The following is a description of a gene set: studied in species Homo sapiens from publication Yevshin I, Sharipov R, Kolmykov S, Kondrakhin Y, Kolpakov F (PMID 30445619) Human Gene Set: SIPA1_TARGET_GENES Genes containing one or more binding sites for (SIPA1) in their promoter regions (TSS -1000,+100 bp) as identified by GTRD version 20.06 ChIP-seq harmonization., and this is the list of marker genes: RNU6-821P, WDR46, MIR548AQ, HMGN1P4, USP2-AS1, RCOR3, IL31RA (interleukin 31 receptor A), NDUFAF8 (NCBI Gene Id 284184), CEP97, USF3, H2AC14, TGIF2, MTCO3P12, TRIM26, EDA, OPTN, TK1 (thymidine kinase 1), CCDC91, DENND3 (NCBI Gene Id 22898), NNT, NUDCD2, H2BC17, MT-TL1, CXCL8, EBLN3P, GLUD1P2, TGFBR1, CYB5A, BICRAL, IQCH, CLUAP1, CACNA1A, KCNK2, HMMR, PIK3C3, EIF4B, API5, LINC02098, KCNJ1, DST, BRD8, LINC00708, LYPLA2P2, HLA-E, H3C12, PARP2, MOSPD3, MRPL2, MMS19, SIPA1, RALGDS, ARMC1, RN7SL418P, KLC4, RNU7-29P, LIN37, SLFN12, ZNF225, TOR2A, DRAIC, FAM117A, PPP1R15A, FAM53C, MNS1, PI4KB, TPX2, ILF2, TBCC, FUZ, TMX2, H2AC17, BTN3A3, AFMID, UBTD1, FAT1, CNBD1, PQBP1, TEPSIN, CDC25C, ADTRP, PTK2, ACTRT3, MED19, DHX30, EYS, RGS20, RPPH1, NEURL1-AS1, TRAPPC6A, TTYH3, CLK1, H2BC14, LINC01234, RPL23AP81, ZNF430, ENSG00000249236, AMBRA1, KAT7, TIMM17B, BMS1P1, PFDN6, BLOC1S3, LINC01934, USP2, ALKBH3-AS1, EML2, MTF1, DMAC2L, CDH1, TAS1R3, KIF20A, TNIP2, ZNF850, LINC01392, NGDN, CCNF, SLC12A8, H2AC21 (NCBI Gene Id 317772), GRIK2, SCAT8, FEZ2, TAS1R2, INPP5B-AS1, NEU1, JPT1P1, ZNF225-AS1, TGFBI, PLOD2, ORC1, ZNF776, NFU1, ANKRD37, AVL9, COX6A1P2, CST8, ANXA2R, H2BC5 (NCBI Gene Id 3017), IK, MTND5P11, PDHX, BTN2A1, ADAMTS6, PRPF38A, MT-ND1, PGR-AS1, NDUFA2, MED25, CLMP, PPIAP52